The following is a description of a gene set: Human Gene Set: GSE43955_1H_VS_60H_ACT_CD4_TCELL_DN Despite their enormous importance, the molecular circuits that control the differentiation of Th17 cells remain largely unknown. Recent studies have reconstructed regulatory networks in mammalian cells, but have focused on short-term responses and relied on perturbation approaches that cannot be applied to primary T cells. Here, we develop a systematic strategy – combining transcriptional profiling at high temporal resolution, novel computational algorithms, and innovative nanowire-based tools for performing gene perturbations in primary T cells – to derive and experimentally validate a temporal model of the dynamic regulatory network that controls Th17 differentiation. The network is arranged into two self-reinforcing and mutually antagonistic modules that either suppress or promote Th17 differentiation. The two modules contain 12 novel regulators with no previous implication in Th17 differentiation, which may be essential to maintain the appropriate balance of Th17 and other CD4+ T cell subsets. Overall, our study identifies and validates 39 regulatory factors that are embedded within a comprehensive temporal network and identifies novel drug targets and organizational principles for the differentiation of Th17 cells. from publication Yosef N, Shalek AK, Gaublomme JT, Jin H, Lee Y, Awasthi A, Wu C, Karwacz K, Xiao S, Jorgolli M, Gennert D, Satija R, Shakya A, Lu DY, Trombetta JJ, Pillai MR, Ratcliffe PJ, Coleman ML, Bix M, Tantin D, Park H, Kuchroo VK, Regev A (PMID 23467089) Genes down-regulated in CD4 T helper cells Th0: 1h versus 60h. species: Homo sapiens, and this is the list of marker genes: VNN1, ELL, FER, SEZ6, KHDC1L, PACSIN1, RHOH, HBS1L, BRAP, YES1, TM4SF1, KCNH2, GPX1, LAMA2, ZBTB12, CRYM, TERF1, IL17RA, SYNPO, MCM3AP, GFRA1, ENDOG, ARNT2, SELENOW, TNFRSF18, PSMC3IP (NCBI Gene Id 51769), IL6ST, CBX5, NEK6, A2M, PTGER4, SAA2, SLC30A1, LCT, POU3F4, HASPIN, OLFM1, EBF3, HMGN5, NFIL3, ITGA7, ITIH3, ZBED3, CUL2, ALG3, CRY2, CTNNA2, BRIX1, PPP1R15A, RAD54L, ERLIN1, COL11A1, PREB, KLF4, DTNB, C1R (complement C1r), CLDN2, GADD45B, ZFAND5, ZNF799, UBE2W, MYD88, KIF1B, BPNT1, CALR, TGFB3, RUFY1, COL4A3, KRT15, YWHAG, PLSCR1, RPS29, CDKN2D, FLOT2, HRAS, CYP27B1, DAZ2, KRT17, DR1, TGFB2, ITPK1, KIFC2, FAM111A, ANKRD13A, CPSF7, RDH5, GALNT2, SERPINA12, DAO, LIMK2, FPGS, SNX12, ALOX12, FICD (NCBI Gene Id 11153), ADIG, SOCS1, ERRFI1, SERPINE2, ERN2, GJA1, ITGAX, IL13RA1, KCNA7, SLURP1, TPH1, ASXL1, RPRM, SLC39A7, IRF1, FDFT1, MTF1 (metal regulatory transcription factor 1), TWIST2, BACH1 (NCBI Gene Id 571), ZNHIT2, IL1RN, HTATIP2, IGLC1, AKAP8L, HBZ, CASP4, ATP9A, PIP4K2C, PPP2R5A, APRT, HTRA2, CCL2, KRT4, CLOCK, STX7, TBX3, P2RY1, KRT84, BLK, TFAP2B (transcription factor AP-2 beta), DAPK2, SLC22A9 (solute carrier family 22 member 9), PPT1, TNFAIP6, TNPO1, GLCE, SLC30A4, REXO1, LIMA1, DIAPH2, TBC1D20, CXCR3, BTG4, CH25H, ONECUT1, UGCG, FKBP11, TAL2, LOXL1, MYL3, LYST, STIL, PEX5, MRPS33, ADH4, TSPAN12, LTBP4, MOBP, COMMD9, DDR1, TUB, DHX36, C5, FSTL3, TNFSF8, CCDC71L, BAAT, DTX1, ACBD6, CD247, PLAA, ERGIC1, CLNS1A, IL4R, WNT4, PRKDC (NCBI Gene Id 5591), MAP3K8, CST9L (NCBI Gene Id 128821), ADGRD1, ZNF821, FNTB, HAUS6, PSPN, PHF7, KCTD9, TGFBR2, PEX11B, ZNF398, ACYP2, FASTK, FOXA2, MIDN, RRP1, PFKFB1, RPL39L